Given this list of marker genes CDKL3, MTHFD1L, UBE2T, SPOCK3, CPNE4, LTV1, MRPL39, DYNC1I1, LSM6, COPG2IT1 (NCBI Gene Id 57183), LINC00869, PRSS27, BAG2, AFG2B (AFG2 AAA ATPase homolog B), PPP1R17, MZB1, KLHL20, LINC01549, FAHD2A, ACP4, SAP30L, RBFOX2, MTFR1, DPEP2, PRTFDC1, ANKRD13A, DNAJC14, FMNL2, PHF24, COLQ, AFAP1-AS1, GAL3ST3 (NCBI Gene Id 89792), ENTREP2, RFTN1, POLE2, GDA, SNTG2, CFL2, ERO1B, ANGPTL1, TFB1M, ACTR6, CSDC2, TSKU, NKTR, TF, LRTM1, ZMYM6, TLR9, ARID2, ZRANB1, CNTNAP5 (NCBI Gene Id 129684), SYT6, ADCK2, CLEC3A, NLN, CD99L2, ATPAF2, DIP2C, NUDT9, SPG11, CARD18 (NCBI Gene Id 59082), SNTG1, COPE, NSD1, SERTAD4, NDUFC1, AQR, LRRN3, ACTN2, AKAP3, ZNF444, IQCA1, TANGO6, ARHGEF25, NECTIN1, KIFC3, SMO, CYP46A1, GOSR1, TMEM144, SIK3, SYT11, MRPL36, MRPL13, OLFML2B (NCBI Gene Id 25903), CSGALNACT2, RIPOR3, KCND1 (potassium voltage-gated channel subfamily D member 1), AGBL5, ST6GALNAC5, DLGAP2, LYRM2, SLC4A5, ERVH48-1, IFT57, MMP27, PHLPP2 (NCBI Gene Id 23035), MED8, B3GNT3, TRIT1, RTN2, SEPTIN10P1, CNTNAP2, PECR, APBB1IP, CDHR2, ECM2, DNALI1, SLC22A16, LGI2, CCDC62 (coiled-coil domain containing 62), NSFL1C, RANBP17, EMC9, SH2B2, FAM167A, INTS13, ZNF83, NIFK, THOC2, MDM1, JPH4 (junctophilin 4), EIF2AK4, PTP4A3, EDDM3B, ZHX2, PAXBP1, PRPSAP2, EMC1, PARVA, STRA6, CDYL, ACTR3B, BRIX1, FA2H, FBXO34, CYP26A1, MARCO, INSIG1, DNAJC27, TRIM5, EPB41L4A, PDE8B, FAIM2, LINGO1, MS4A14, SIPA1L2, NAGPA, SST, DENND5A, PHF20L1, BUB1B, LPIN1, NMNAT2, WNT6, CD93, MS4A6A, HEBP1, ECEL1, RBCK1, SLC16A10, NDE1, TMEM163, DHX58, KLHL41, TPD52L1, AAR2, FARP2, SEZ6L2, LANCL1, MSH5, SLC7A6OS, RPH3A, SFXN3, RBP4, NTF3, TRPM1, GALNT13, FOXG1, FLRT3, KLF1, TFR2, GJB5, VDAC3, OGDHL, ZKSCAN5, SSX3, KIAA1210, VAPB, ATG4D, ANKRD11, BBOX1, ANGEL1 (angel homolog 1), DCX, NRIP3, GDAP1L1, PBRM1, HOXC10, CNTN3, HINFP, RASGRP3, DUS4L, FAXC, GPRC5D, CLDN15, LIM2, PANK1, PDE8A, ZFP91, ARMCX5, TH, HSPA4L, TOX4, GRAMD1B, CENPJ, DDIT3, here is a description of the gene set: Human Gene Set: MODULE_389 studied in species Homo sapiens Breast cancer expression clusters.